Given this list of marker genes HSPD1, TIMM21, PEX6, DNAJC15, TIMM23B, PEX14, TIMM23, PEX2, AIFM1, TIMM44, TOMM20, GFER, TOMM40L, TOMM22, DNAJC19, ROMO1, CHCHD4, TOMM70, PEX1, LONP2, PEX5, PEX12, HSPA4, USP9X, PEX5L, TOMM7, TIMM50, PEX7, PEX10, DNLZ, TIMM17A, GRPEL1, TOMM20L, HSP90AA1, PEX13, PEX16, GRPEL2, PEX26, TOMM40, TRIM37, PAM16, TIMM17B, SAMM50, here is a description of the gene set: The directed movement of proteins into an intracellular organelle, across a membrane. Human Gene Set: GOBP_PROTEIN_TRANSMEMBRANE_IMPORT_INTO_INTRACELLULAR_ORGANELLE species: Homo sapiens